The following is a description of a gene set: studied in species Mus musculus Mouse Gene Set: GOCC_NUCLEOLUS A small, dense body one or more of which are present in the nucleus of eukaryotic cells. It is rich in RNA and protein, is not bounded by a limiting membrane, and is not seen during mitosis. Its prime function is the transcription of the nucleolar DNA into 45S ribosomal-precursor RNA, the processing of this RNA into 5.8S, 18S, and 28S components of ribosomal RNA, and the association of these components with 5S RNA and proteins synthesized outside the nucleolus. This association results in the formation of ribonucleoprotein precursors; these pass into the cytoplasm and mature into the 40S and 60S subunits of the ribosome., and this is the list of marker genes: Cps1, Alkbh4, Zfx, Zfp174, Traip, Rps2, Dnttip1, Aen, Scn5a, Coil, Podxl, Hus1, Taf1b, Rsl1d1, Kri1, Gprc5a, Hmgb2, Ifi213, Pidd1, Car9, Utp3, Bcl6, Ccdc137, Zfa-ps, Isg20, Traf4, Llph, Mdfic, Hltf (NCBI Gene Id 99533), Senp5, Nup153, Trim24, Hsd3b4, Gjb4, Itpr3, Nop58, Carf, Wdr55, Rgs22, Pop5, Capg, Exosc10 (NCBI Gene Id 50912), E2f5, Rbmyf3, Eef1e1, Pym1, Zfp655, Atm, Nufip1, Sbds, Rbm34, Itpr1, Fam32a, Nfx1, Sprn, Imp4, Adad2, Ppp1cb, Dusp11, Ypel4, Endov, Tcof1, Zfp175 (zinc finger protein 175), Rrp1, Bud23, Atxn3, Krr1, Gtf3c3, Mtdh, Klhl7, Arid5a, Rgs2, Ckap2, Cd2bp2, Lin28a, Inka2, Rpl3, Rpf1, Rps19bp1, Rps11, Pdha2, Mak16, Ran, Ppp1ca, Midn, Cmpk1, Rrn3, Bnc2, Utp18, Stag2, Parn, Arl4a, Pth1r, Meak7, Tsen2, Nanog, Prkrip1, Casp7, Fancd2, Rps4l, Npm2 (nucleophosmin/nucleoplasmin 2), Rsl24d1, Mus81, Arl14ep, Pdk3, Gpatch4, Anapc11, Gar1, Exosc3 (NCBI Gene Id 66362), Abl1, Ino80e, Spty2d1, Snrpb2, Trp53tg5, H1f4, Gon4l, Cd2ap, Slbp, Sp140l1, Cutc, Rrp7a, Rps8, Ilf3, Rpl34-ps2, Kdm5d, Wdr33, Elp3, Zrsr2, H1f8, Stag3, Mycs, Apex1, Dab2, Hirip3, Rpp14, Snrnp35, Sertad3, Eif3a, Uba2, Alkbh2, Wdr18, Zfp771, Ifi204, Kit, Ppp1r26, Trp53, Plscr2, Zcchc7, Trp53inp1, Chtop, Aptx, Ilf2, Chp2, Tsg101, Pop1, Nek2 (NIMA (never in mitosis gene a)-related expressed kinase 2), Ccdc86, Chd7, H1f5, Rpl11, Gper1, Eef1a1, Rdm1, Mki67 (NCBI Gene Id 330663), Diaph2, Fmr1, Oxr1, Relt, Esf1, Rbm14, Zfp819, Dffb, Lrp1, Mad2l1bp, BC004004, Usp17la, Pim1 (NCBI Gene Id 18712), Shld3, Nwd1, Tmem65, Pa2g4, Pwp1, Polr1e, Kat6a, Dctn3, Ldb2, Btbd10, Rps24, Rpp30, Grwd1, Upf3b, Exosc1, Rad17, L3mbtl3, Doc2a, Mif4gd, Tsr1, Taok2, Mbd6, Brd4, Pomt2, Ptprj, Gtpbp4, Nhej1, Heatr1 (NCBI Gene Id 94251), Myo10, Setx, Dnttip2, Nacc2, Ddx49, Upf3a, Ehmt2, Sp100, Ddx23, Ifi35, G2e3, Zcchc4, Nucks1, Orc4, Rps17, Zfp677, Sirt7, Nin (ninein), Selenbp2, Spc24, Fgf18, Nop53, Syne1, Nop14, Ddx5, Mrpl23, Kdm2b, Smarca4, Tent4b, Narf, Rxrb, Gtf3c1, Dock4 (dedicator of cytokinesis 4), Dhx9, Rbmx2, Blm, Pimreg, Knop1, Nop16, Ngdn, Sp140l2, Nfkbie, Smc2, Mettl18, Tax1bp3, Twist2, Capn3, Zfp207, Smarcb1 (NCBI Gene Id 20587), Magi1, Ttf1, Adarb2, Ppp1r12a, Llph-ps1, Myg1, Malt1, Parp3, Noc4l, Utp14a, Abcb8, Ifi208, Rpp38, Rpl36, Ddx47, Naa50, Rreb1, Zeb2, Srsf5, Scd1, Arl4d, Tert, Spata2, Nono, Hsd3b6, Zfp692, Ypel2, Pola1, Dhx15, Usp36, Rcn2, Ddb1, Mnx1 (motor neuron and pancreas homeobox 1), Mbd1, Nlrp5 (NLR family, pyrin domain containing 5), Cradd, Aopep, Eme1, Casp2, Camkmt, Rpl7l1, Eif6 (eukaryotic translation initiation factor 6), Ddx56, Snu13, Rbm4, Tnpo1, Rps5, Dnaaf5, Cpne3, Pcdh1, Zfp758, Aff4 (NCBI Gene Id 93736), Plk5, Bop1, Pinx1, Tmub1, Rnf169, Rps6ka6, Rpl5, Nom1, Mdm2, Nop2, AU040320, Top2b, Prmt6, Taf1a, Wt1, Nedd1, Plk4, Ddx10, Rps3, Bnc1, Nkrf, Gon7, Adad1, Zpr1, Ddx31, Scaf11, Rbmy (NCBI Gene Id 19658), S100a16, Hspa9, Cdc14a, Daxx, Plcz1, Smug1, Tsen34, Mrto4, Dnaaf2, Pop7 (processing of precursor 7, ribonuclease P family, (S. cerevisiae)), Dnajc2, Batf3, Pno1, Utp6, Tut4, Wrn, Herc4, Ppp1cc, Brix1, S100a13, Zfp277, Bysl, Taf4b, Fkbp6, Ddx46, Rpl4 (ribosomal protein L4), Hsd3b2, Ppm1b, Axin1, Tent4a, Rps12, Trerf1, Pou5f1, Prdm5, Pex14, Nusap1, Abt1, 1700013H16Rik, Fbxl22, Polr1c, Vdr, Mxi1, Gorab, Atxn1, Klf6, Hus1b, Kif18b, Atp5mj, Ccnd2, Golga3 (NCBI Gene Id 71391), Fbxw7, Rbl2, Ccno, Ubtf, Nub1, Dcaf17, Mbd3, Drosha, Dimt1, Nhp2, Rpp40, Ang, Trim28, Hap1, Dnajb1, Xpo6, Hsd3b1 (NCBI Gene Id 51882), Camta1, Myo1c, Baz2a, Dedd, Hdhd3, Cox7a2l, Tspyl1, Rbmyf2, Pus1, Lsm6, Nsd2, Mcrs1 (NCBI Gene Id 97957), Utp15, Rasl11a, Bnip2, Nf2, Rps3a1, Arhgap33, Rcl1, Snx15, Cetn3, Nsun2, Osbp, Atf3, Rpl36-ps12, Mro, Arl2 (NCBI Gene Id 80563), Mcm10, Ccr2, Rrp12, Rpl27, Eef1d, Leo1, Selenbp1, Ddx21, Stat1, Gtf2h5, Gzf1, Taf1d, Nol12, Nepro, Rbmyf9, Gli3, Kdm7a (NCBI Gene Id 338523), Nip7, Nudt16, Gpatch2, Spin1 (spindlin 1), Actr6, Skp2, Atxn7, Rpp21, Ddx51, Ifi203-ps, Mrps31, Mndal, Nifk, Iqsec1, Ddx52, Ppm1e, Spg11, Suz12, Tbp, Gemin2, Lbr, Dis3, Polr1h, Pou2f3, Zmat3, Setd7, Rrp8, Fen1, Usp17lb, Mks1, Ddx24, Usp17ld, Uchl5, Abhd14b, Ifi211, Tsen54, Timm44, Riox2, Exosc2, Ergic2, Samd4, Mphosph10 (NCBI Gene Id 70501), Otp, Rgs12, Terf1, Tmem179b, Rbm4b, Orc6, Nova1, Rps6-ps4, Adar, Kat5, Top1, Txn2, Txnrd1, Pih1d1, Ubd, Taf1, Snapc5, Rexo2, Syne2, Ddx55, Sin3a, Katnbl1, Macroh2a1, L3mbtl1, Nat10, Setmar, Cbx5, Pkmyt1, Stk24, Timm13, Pelp1 (proline, glutamic acid and leucine rich protein 1), Hsd3b5, Vps51, Rfpl4, Mrps27, Gli2, Cask, Utp11, Nfic, Oard1, Gnl3, Zfp106, Flna, Zcchc17, Anp32b, Cipc, Fyttd1 (NCBI Gene Id 98031), Rps10, Pik3cb, Zcchc9, Rps27a, Rsad2, Liat1 (ligand of ATE1), Mphosph6, Edf1, Eif3l, Sap30l, Fgf22, Rpl34, Pycard, Thap1, Bmal2, Snai1, Fcf1, Dyrk1b, Rps9, Bms1, Sumo1, Etv4, Zfp593, Cby1, Smg6, Pafah1b2, Dcaf1, Pank1 (pantothenate kinase 1), Foxa1, Nop10, Mtx2, Mars1, Nol4, Ifi205, Scd3, Retreg1, Ang6, C2cd4a, Srp54a, Rgcc, Ccny, Mtrex, Rpl18, Nob1, Zfp354a, Trmt10a, Pwp2, Urb2, Mybbp1a, Kmt5b, Ewsr1, Cdk5, Las1l, Cog7, Cenph, Polr1g, Pak1ip1, Rabgef1, Epc1, Nr4a1, Vrk1, Cep85, Nek11, Gabrg3, Stau2, Noc2l, Kat7, Slx9, Rora, Chd3, Sptbn1 (NCBI Gene Id 268394), Ttc3, Cln6, Rars1, H1f0, Srp72, Ercc6, Rab8a, Imp3, Ppid, Sirt1, Sub1, Rpl12, Tcea1, Rpl13-ps6, Wdr46, Rnmt, Ldoc1, Rnf213, Tulp3, Wiz, Bckdhb, Nmd3, Morf4l2, Tspyl2, Washc2, Ciapin1, Xrcc1, Foxj2, Zfp935, Pak6, Phf5a, Grb2, Rev3l, Rpap2, Polr2h, Gnl2, Eri1, Pdha1, Senp3, Sp140, Smarca5, Polr1f, Mrps9, Thap2, Mbd2, Rtf1, Nr1h3 (nuclear receptor subfamily 1, group H, member 3), Mrps15, Ggn, Dynlt4, Cebpa, Hsd3b8, Polr1a, Rps15a, Apex2, Mtus1, Frg1, Ang5, Wdr12, Lyar, Wdr36, Ube2i, Polr1b, Ctcf (NCBI Gene Id 270092), Lin28b, Polr2a, Pum3, Pin4, Rbm10, Bend3, Mri1, Zfp385a, Utp20, Naa10, Srp68, Gprc5b, Pnma2, Pax9, Nol11, Dgkq, Nf1, Lrwd1, Stn1, Ckap5, Jmjd6, Tgs1, Fmn2, Ttc8, Rexo5, Ifi214, Ppm1d, Rbmyf1, Sirt6, Etv6, Ip6k1, Habp4, Rnf20, Ikbip, Hspa8, Nfib, 2810004N23Rik, Baz1b, Chrm2, Ssrp1, Dtl, Llph-ps2, Srpk2, Tra2a, Rpl26, Pes1, Arfip2, Nsun5, Ube2t, Npm1, Srsf9, Ppp1ccb (NCBI Gene Id 434233), Ints4, Jazf1, Six1, Adarb1, Pnma1, Wdfy1, Aatf, Sdcbp2, Mdn1, Ino80b, Parp1, Parp2, Tbl3, Utp23, Rps6ka3, Dhx33, Snapc1, Arhgap32, Ddx17, Sirt2, Wdr75, Zbtb11, Toe1, Cdca8, Cdca7l, Nolc1, Bcl9l, Wdr82, Polr2i, Rbmyf6, Exosc6 (exosome component 6), Wdr74, Phlda1, Dync2i2, Nol8, Sapcd2, Nrde2, Gemin4, Thumpd3, Ifi209, Zbtb33, Hjurp, Snord87, Nsa2, Xrcc6, Rps27, C1d, Maged2, Gnai3, Meaf6, Myc, Nol10, Mycn, Rasl10a, Hoxd9, Cyb561a3, Lipa, Cdkn2aip, Rps14, Macrod2, Nol6, Rpl34-ps1, Cbfa2t3, Runx3, Cdkn2a, Rrp9, Znrf2, Kif2b, Zfp91, Pdcd11, 2200002D01Rik, Rad51, Ak6, Tcim, Rpl7a, Sdad1, Usp14, Rps28, Fam193b, Zfp346, Xpo1, Npm3, Phf8, Hsd3b3, Gcfc2, Pop4, Cdk7, Ang2, Vmp1, Smad7, Zfp330, Rps19, Tsen15 (tRNA splicing endonuclease subunit 15), Pnkp, Plscr1, Tex10, Deaf1, Riox1, Arfgef1 (NCBI Gene Id 226334), Dedd2, Zfp622, Krt18, Rara, Hsd3b9, Ola1, Kdm4a, Xrcc5, Cdc14b, Abtb1, Nol3, Rpl6, Polr2k, Pnma3, Cilk1, Med1, Paf1, Zfp202, Ddx11, Sfr1, Ublcp1, Hinfp, Ifi207 (NCBI Gene Id 98407), Firrm (NCBI Gene Id 381306), Exosc9, Rrp1b, Ddx50, Cc2d1a, Cenpp, Akap8, Camk4, Lrrc34, Get4, Cul2 (NCBI Gene Id 75720), Mphosph8, Idh3g, Cemip, Zmynd8, Acsl5, Xrn2, Ier5, Fam111a, Trim41, Larp4b, Map3k14, Zzz3, Hoxb5, Sun1, Surf6, Gtpbp10, H1f10, Wdr3, Slc30a5, Ptpn13, Med27, Ptpn6 (protein tyrosine phosphatase, non-receptor type 6), Sdha, Ager, Itgb4, Dclre1a, Lmo1, Prdm1, Kif2a, Rps23, Gnl3l, Nle1, Gnai1 (NCBI Gene Id 14677), Ubxn8, Plrg1, Zfp397, Polr2f, Rps25, Mbip, Mysm1, Rexo4, Fancg, Spats2l, Tdp2, Nrip1, Urb1, Sf3b1, Exosc5, Noc3l, Akap11, Esrra, Letmd1, Ston2, Dnajc21, Zc3h14, Utp14b, Rerg, Ddrgk1, Filip1, Scd4, Zfp715, Mak, Rrp36, Rbis, Pspc1, Sf3b3, Eid3, Tut1, Rbbp6, Cerkl, Nop56, Wdr43, Nvl, Emx1, Exosc8, Nrxn1, Prmt7, Rbpj, Btd, Rbmyf8, Fbxo11, Get3, Trim27 (tripartite motif-containing 27), En2, Rbmyf7, Ncl, Sdhaf2, Vhl, Brwd1, Fblim1, Cdk8, Eif4a3l2, Mob2, Airim, Usp17le, Emg1, Agpat5, Cemip2, Nol9, Nol7, Oasl1, Ankrd1, Taf13, Exosc7, Bcas2, Hand1, Mllt1, Rpl19, Ctsl, Specc1, Rbm19, Top2a, Zbtb14, Cdkn1a, Fbl, Cdk5rap3 (NCBI Gene Id 97738), Rpl13, Wbp11, Acadvl, Fhit, Bmyc, Plekhm1, Ebna1bp2, Rpf2, Snord21, Abcc4, Tbca, Zfp982, Surf2 (NCBI Gene Id 20931), Ifi206, Haus7 (HAUS augmin-like complex, subunit 7), Akna, Rbm28, E2f8, Rpain, Phf6, Map1s, Polr2e, Arl6ip4, Ftsj3, Rai14 (retinoic acid induced 14), Rbbp5, Dkc1, Chchd1, Utp4, Ip6k2, Ell3, Cpt2, Srp19, Ddx54, Eya2, Cox10, Uso1, Ippk, C1qbp, Rps6, Tma16, Txk, Stox1, Ddx18, Zbed6, Cenpw, Suv39h1, Parp10, Exosc4, Ccnt1, Rps4x, Dcaf13, Ezr, Nuak1, Taf1c, Nop9, Wee1, Zfp641, Cstb, Phf2, Ppan (peter pan homolog), Homez (NCBI Gene Id 239099), Dek, Cd180, Snapc3, Cdk4, Rbmyf5, Pml, Mapkbp1, Mrpl40, Rps13 (NCBI Gene Id 68052, ribosomal protein S13), Rpp25, Rps16, N4bp1, Dhx37, Atp8b2, Dsn1, Kdm5a, Acin1, Isg20l2, Ddx28, Rcc2, Spata24, Scd2, Nox4, Utp25 (NCBI Gene Id 98643), Mettl22, Usp17lc, Foxi1, Polr1d, Prkdc, Tfip11, Rae1, Sesn1, Nbn, Mettl1, Rps7, Acaca, Mrm2, Ifi203, Polr2l, Mettl5, Zfp146, Rpl23, Ddx27, Dgcr8 (NCBI Gene Id 94223), Wdfy3, Atxn1l, Eif4a3 (NCBI Gene Id 76481), Dnajb9, Gle1, Rrs1, Kif20b, Agtpbp1, Xpc, Trim68, Ypel3, Ang4, Fbll1, Eif4a3l1, Stk35, Plk3, Clec3b